Given this list of marker genes APOE, ADRA2C, MIR30C1, HMGCR, FOXO1, RHBDF2, MIR19A, GNAO1, KCNJ11, ACVR1C, MIR146A, MIR766, CHGA, CYP51A1, KLF7, MIR29B1, DRD2, KCNB1, SREBF1 (sterol regulatory element binding transcription factor 1), OPRM1, DPH3, IRS1, MIR199A1, BMP8A, JAGN1, NPFF, GNAZ (NCBI Gene Id 2781), GHRL, SYT4, FFAR2, SIRT4, MTNR1B, INHBB, MIR19B1, FKBP1B (NCBI Gene Id 2281), GNAI1, PIM3, ADRA2A, F2R, INS, DRD3, RAB11FIP1, HADH, VSNL1, DRD4, PFKL, F2RL1, ADTRP, REST, RAB11FIP5, ENY2, IL12A, RSAD2, NR1H3, NDUFAF2, CCN3, PRKN, PTPN11, RHBDF1, RAB11FIP3, ERP29, NEO1 (neogenin 1, NCBI Gene Id 4756), PDE8B, IL1B, MIDN, CD200, FRMD4A, MIR93, UCP2, FAM3D, SYTL4, IDH2, GHSR, SERGEF, PSMD9, IL12B, ABCC8, here is a description of the gene set: Any process that stops, prevents, or reduces the frequency, rate or extent of the controlled release of a protein from a cell. Human Gene Set: GOBP_NEGATIVE_REGULATION_OF_PROTEIN_SECRETION species: Homo sapiens